Given this list of marker genes MTTP, APOB, CETP, APOF, P4HB, LPA, here is a description of the gene set: part of: Plasma lipoprotein remodeling studied in species Homo sapiens Reactome Pathway: LDL remodeling LDL (low density lipoproteins) are complexes of a single molecule of apoprotein B-100 (apoB-100) non-covalently associated with triacylglycerol, free cholesterol, cholesterol esters, and phospholipids. CETP (cholesterol ester transfer protein) complexed with cholesterol esters interacts with an LDL (low density lipoprotein) particle, acquiring triacylglycerol molecules and donating cholesterol ester to the LDL, a key step in the transport of tissue cholesterol to the liver.<br>As an alternative to LDLR-mediated uptake and degradation, a LDL particle can bind a single molecule of LPA (apolipoprotein A), forming a Lp(a) lipoprotein particle.